Given this list of marker genes Slc7a11, Xkr8, Cfh, Btk, Ccr2, Gcnt4, Lilrb4a, Hmgb1, Pik3cb (phosphatidylinositol-4,5-bisphosphate 3-kinase catalytic subunit beta), Itgam, Axl, Pik3cd, Slc37a4 (NCBI Gene Id 14385), Mecom, Fcgr2b, Csf1r, Hc (NCBI Gene Id 15139), Cxcr2, Mertk, Hcar2, Itpkb, Pde4b, Il6, Tspan9, Sh2b3, Jam3, Csf1, Il18, Ifng, Cd44, Fam3d, Mthfd1, Anxa1, Mpl, here is a description of the gene set: The process of regulating the proliferation and elimination of neutrophils such that the total number of neutrophils within a whole or part of an organism is stable over time in the absence of an outside stimulus. studied in species Mus musculus Mouse Gene Set: GOBP_NEUTROPHIL_HOMEOSTASIS